The following is a description of a gene set: Human Gene Set: GAVISH_3CA_METAPROGRAM_MACROPHAGES_LIPID_ASSOCIATED Genes upregulated in subsets of cells of a given type within various tumors In this study, an extensive analysis was conducted to define meta-programs (MPs) capturing intra-tumor heterogeneity across a spectrum of tumor types. The approach utilized non-negative matrix factorization (NMF) to analyze each cell type separately within individual tumor samples. This involved the analysis of malignant cells, macrophages, fibroblasts, endothelial cells, epithelial cells, T-cells, and B-cells. NMF was executed with varying parameter values (K=4, 5, 6, 7, 8, 9), thereby generating 39 programs for each cell type per sample. Each NMF program was summarized by the top genes based on NMF coefficients.\nRobust MPs were then delineated for each cell type using a set of stringent criteria, including recurrence within the same tumor, similarity to programs in other tumors, and non-redundancy within a tumor. Subsequently, these robust NMF programs were clustered (per cell type) based on Jaccard similarity, leading to the identification of MPs associated with each cell type.\nTo enhance the quality of the MPs, a refinement steps were undertaken, involving the removal of MPs suspected of reflecting low-quality data (with an overrepresentation of ribosomal proteins or mitochondrial-encoded genes), single-study inclusion, or similarity to miss-annotated cell types. from publication Gavish A, Tyler M, Greenwald AC, Hoefflin R, Simkin D, Tschernichovsky R, Galili Darnell N, Somech E, Barbolin C, Antman T, Kovarsky D, Barrett T, Gonzalez Castro LN, Halder D, Chanoch-Myers R, Laffy J, Mints M, Wider A, Tal R, Spitzer A, Hara T, Raitses-Gurevich M, Stossel C, Golan T, Tirosh A, Suvà ML, Puram SV, Tirosh I (PMID 37258682) species: Homo sapiens, and this is the list of marker genes: CD163, C1QC, C1QB, PLD3, NUPR1, GM2A, CCL3, GPR34, APOC1, GCHFR, ASAH1, MS4A4A, APOE, C2, TMEM176B, LIPA, RNASE1, GPNMB, STAB1, SLC40A1, CTSL, DAB2, CTSD, A2M, CYP27A1, ACP5, FOLR2, VSIG4, C1QA (NCBI Gene Id 712), CFD, F13A1, CTSC, NPL, SPP1, TREM2, PLA2G7, SELENOP, FUCA1, MSR1, FCGR3A, CD9, CCL18, LGALS3, CD14, CREG1, CD59, IFI27, LGMN, PLTP, SLCO2B1